The following is a description of a gene set: species: Homo sapiens Heme signaling Human Gene Set: REACTOME_HEME_SIGNALING, and this is the list of marker genes: TBL1XR1, CREBBP, NCOA6, APOA1, MEF2C, HBB, NCOA2, CRTC3, NR1D1, MEF2D, EP300, HBA1, CARM1, HDAC3, SMARCD3, CLOCK, BACH1, USP46, TBL1X, RORA, NRIP1, TGS1, CRTC1, HBA2, NPAS2, CLEC1B, NCOA1, NCOR1, SIRT1, LY96, PGRMC2, ATF2, APOB, HMOX1, XPO1, TLR4, HELZ2, MAFK, CRTC2, BMAL1, MED1, PPARA, CREB1, CHD9, SLC46A1, PPARGC1A (NCBI Gene Id 10891), RAI1, NFE2L2, RXRA